Given this list of marker genes SELENBP1, C4A, RND1, MLPH, SYBU, GREB1, GAMT, GDF15, PDZK1, ADIRF, RET, GPRC5A, ARMT1, TNNT1, SLC7A8, KRT18, CYP2B6, DHRS2, CLGN, DUSP4, CACNG4, MUC1, IFT122, SLC39A6, SCGB1D2, ERBB4, SEMA3C, TJP3, BCL2, EEF1A2, AZGP1, DNAJC12, SYT17, TTC39A, DNALI1 (NCBI Gene Id 7802), PEX11A, HEMK1, TFF3, SCUBE2, IFT74, EVL (NCBI Gene Id 51466), CYP2B7P, SIDT1, DACH1, STK32B, SCNN1A, RHOB, SPDEF, BMPR1B, CCDC170, SEMA3B, MAST4, ACOX2, ACADSB, SSH3, SLC27A2, PIERCE1, GATA3, ELAPOR1, SERPINA5, TOX3, CERS4, SYT1, CFD, MAPT, CACNA1D, UGCG, PRR36, KCNE4, AREG, TPSAB1, CA12, GALNT7, ANXA9, CRIP1, NAT1, SCGB2A2, ABAT, STC2, SLC4A8, C1orf21, MYO6, SCCPDH, TFF1, ESR1, GPC1-AS1, PIP, ELOVL2, MYB, PGR, SLC16A6, CHAD (chondroadherin), INPP4B, CLSTN2, PNPLA4, TMC5, CFB, AGR2, CYBRD1, VAV3, SLC44A4 (solute carrier family 44 member 4), AR, EPS8L1 (EPS8 signaling adaptor L1), TSPAN1, TBC1D9, MAP3K12, GFRA1, ALCAM, FBP1 (NCBI Gene Id 2203), CELSR1, PBX1, here is a description of the gene set: Human Gene Set: DOANE_BREAST_CANCER_ESR1_UP from publication Doane AS, Danso M, Lal P, Donaton M, Zhang L, Hudis C, Gerald WL (PMID 16491124) species: Homo sapiens Little is known of the underlying biology of estrogen receptor-negative, progesterone receptor-negative (ER(-)/PR(-)) breast cancer (BC), and few targeted therapies are available. Clinical heterogeneity of ER(-)/PR(-) tumors suggests that molecular subsets exist. We performed genome-wide expression analysis of 99 primary BC samples and eight BC cell lines in an effort to reveal distinct subsets, provide insight into their biology and potentially identify new therapeutic targets. We identified a subset of ER(-)/PR(-) tumors with paradoxical expression of genes known to be either direct targets of ER, responsive to estrogen, or typically expressed in ER(+) BC. Differentially expressed genes included SPDEF, FOXA1, XBP1, CYB5, TFF3, NAT1, APOD, ALCAM and AR (P<0.001). A classification model based on the expression signature of this tumor class identified molecularly similar BCs in an independent human BC data set and among BC cell lines (MDA-MB-453). This cell line demonstrated a proliferative response to androgen in an androgen receptor-dependent and ER-independent manner. In addition, the androgen-induced transcriptional program of MDA-MB-453 significantly overlapped the molecular signature of the unique ER(-)/PR(-) subclass of human tumors. This subset of BCs, characterized by a hormonally regulated transcriptional program and response to androgen, suggests the potential for therapeutic strategies targeting the androgen signaling pathway. Genes up-regulated in breast cancer samples positive for ESR1 compared to the ESR1 negative tumors.